Given this list of marker genes RILPL1, GIPC1, NOTCH2NLC, LRP12, PABPN1, here is a description of the gene set: Human Gene Set: HP_PROGRESSIVE_PTOSIS Progressive ptosis A progressive form of ptosis. studied in species Homo sapiens